Given this list of marker genes DNAJC9, TLE1, EIF3B, MIS18A, SIVA1, RFC4, MTCH1, CCNF, POLA2, PSRC1, PSMC3IP, NOP56, PRPF4, CHERP, BAZ1A, DLEU2, CTPS1, SPAG5, CHAF1A, POLR2H, SART3, THAP11 (NCBI Gene Id 96844), NEMP1, SP1, OGFOD1, MCM2, PPIF, CDC45, MTFP1, TIMELESS, CCDC167, RBCK1, ESF1, WDR4, RPRD1A, JADE1, BLM, RCC1L, RECQL4, CARD9, DDX23, SGO2, NOTUM, SF3B3, NCAPD2, PHF19, CCDC59, MIR9-1HG (MIR9-1 host gene), CORO2A, KNL1, ERLIN1, TRIM29, ANP32B, NUP85, MIR770, ADRA2C, HPGD, CENPU, PRPF3, ST3GAL4, REEP4, SLC25A38, EPB41L2, HMGXB4, PINX1, OLFM1, GLO1, FUS, GGA2, DLX6, FETUB, PPAN, ZNF536, HSCB, TOE1, POLQ, MGME1, CPSF4 (NCBI Gene Id 10898), TIMM50, DTYMK, MRPS34, CDC26, ANGPTL2 (angiopoietin like 2), CHGA, NCAPG2, NPRL2 (NCBI Gene Id 10641), SNHG10, SNRNP25, AURKB, SMCR8, DDN, HNRNPM, CDCA5, SKA1, SERTAD4, TBC1D2B, DSCC1, ZNF426, SNCA, STK39, FOXRED2, NUCKS1, MCM5, QKI, B3GALNT2, U2AF1, NAA38, ELAVL1 (NCBI Gene Id 1994), COASY, CISD3, DUS3L, CDC20, JMJD6, TTLL12, VPS37A, TTF1, CASP3, FHL1P1, COQ4, EZH2, ING5, KIF4A, RBM17, EMC8, SNW1, TRIM59, TARBP2, DOK4, NUP88, COQ10A, DIS3L, NUP43, RRM1, UNG, FAM43A, RBM33, RWDD1, RSL1D1, CAMK4, PPP6C, GLA, BUD31, CACNB2, UBE3D, GNL2, CTNNBL1, ENTHD1, MCM8, FEN1, CCDC150, PRR11, RUVBL1, SLC1A5, KPNB1, NUSAP1, POU5F1P4, HAUS8, ZNF394, MRPL37 (NCBI Gene Id 51253), MCM10, HMBS, MALSU1, INVS, TCF19 (transcription factor 19), CMTM7, PGP, SAV1, BRCA1, GNL3, MRM3 (mitochondrial rRNA methyltransferase 3), UTP14A, PMS1, STARD7, SLC29A1, XRCC5 (X-ray repair cross complementing 5), KNTC1, TMEM109, HSP90AA1 (NCBI Gene Id 89272), CABLES1, NDE1, ITGB3BP, TICRR, ATIC, NACA4P, HADH, PATL1, NOM1, ANAPC1, CDCA4, TJAP1, EBF3, NRP1, LRRC59, TOR3A, DNAJC2, ASPM, CENPJ, here is a description of the gene set: Removal of the transcription factor SAP1a member of the Ternary Complex Factor (TCF) group of transcription factors which in conjunction with Serum Response Factor (SRF) has been shown to have a profound effect on positive selection in the thymus. When another TCF Elk1 is knocked out in mice there is no effect on positive selection unless it is on a Sap1a KO background where the phenotype is very severe. We have stimulated isolated double positive T cells (DPs) with anti-CD3 to mimic positive selection and compared basal and stimulated transcription across the four genotypes to discover the downstream targets of Sap1a involved in positive selection. from publication Costello P, Nicolas R, Willoughby J, Wasylyk B, Nordheim A, Treisman R (PMID 20554967) studied in species Homo sapiens Genes down-regulated in untreated double positive thymocytes: ELK1 knockout versus ELK1 and ELK4 knockout. Human Gene Set: GSE21546_ELK1_KO_VS_SAP1A_KO_AND_ELK1_KO_DP_THYMOCYTES_DN